Given this list of marker genes SLC10A1, ST8SIA1, ECM2, CD80, LAIR1, SMPD2, ESRRA, SNAPC1, SNAPC3 (small nuclear RNA activating complex polypeptide 3), GDI2, ST6GAL1, BCL10, RNASE4, SMARCD1, GCM1, GNRHR, SNRPB2, SNCG, here is a description of the gene set: Genes up-regulated in A172 cells (glioma, does not express MGMT) by carmustine at 48 h. species: Homo sapiens Human Gene Set: BANDRES_RESPONSE_TO_CARMUSTIN_WITHOUT_MGMT_48HR_UP Chemotherapy with the alkylating agent BCNU (1,3-bis (2-chloroethyl)-1-nitrosourea) is the most commonly used chemotherapeutic agent for gliomas. However, the usefulness of this agent is limited because tumor cell resistance to BCNU is frequently found in clinical brain tumor therapy. The O6-methylguanine-DNA methyltransferase protein (MGMT) reverses alkylation at the O6 position of guanine and we have reported the role of MGMT in the response of brain tumors to alkylating agents. However, the different mechanisms underlying the patterns related to MGMT remain unclear. To better understand the molecular mechanism by which BCNU exerts its effect in glioma cell lines according MGMT expression, we used microarray technology to interrogate 3800 known genes and determine the gene expression profiles altered by BCNU treatment. Our results showed that treatment with BCNU alters the expression of a diverse group of genes in a time-dependent manner. A subset of gene changes was found common in both glioma cell lines and other subset is specific of each cell line. After 24 h of BCNU treatment, up-regulation of transcription factors involved in the nucleation of both RNA polymerase II and III transcription initiation complexes was reported. Interestingly, BCNU promoted the expression of actin-dependent regulators of chromatin. Similar effects were found with higher BCNU doses in MGMT+ cell line showing a similar mechanism that in MGMT-deficient cell with standard doses. Our data suggest that human glioma cell lines treated with BCNU, independently of MGMT expression, show changes in the expression of cell cycle and survival-related genes interfering the transcription mechanisms and the chromatin regulation. from publication Bandres E, Andion E, Escalada A, Honorato B, Catalan V, Cubedo E, Cordeu L, Garcia F, Zarate R, Zabalegui N, Garcia-Foncillas J (PMID 15980968)